Given this list of marker genes SKIC2, THOC1, EIF3H (NCBI Gene Id 8667), NEK11, MRPS18B, LETMD1, CYREN, RIN2, MOV10, GOLT1B (golgi transport 1B), NUDT5, RALY, SETDB1, WSB1, ZNF518A, TMEM87A, NAA20, MARK2, BBS4, RARB, MRPS31, OXNAD1, RECQL5, FBXO38, ZNF24, BANF1, ZSCAN9, COPS5, USP48, DLEU2, YTHDC1, TXNL1, SPAG7, ZNF615, GORAB, CWF19L1 (NCBI Gene Id 55280), HCK, NUP155, TRAPPC1, THRAP3, NME7, CHMP2B, NEPRO, RNF20, NELFE, MBD1, HOXA1, ARPC4, NECAP1, PDCD10, LINC00877, NUDT2, SERPINI1, KNTC1, SHCBP1 (NCBI Gene Id 79801), OS9, MCTS1, ZNF600, MTPN, PPP2R3C, MUL1, ARL14EP, FLCN, ERCC1, MYOF, SLC26A6, GOSR2, SELENOK, CLPTM1 (NCBI Gene Id 1209), DCTN4, VPS41, THUMPD3, SUPV3L1, ZNF222, CCNT1, CDC123, KRR1, CCDC174, UBR1, H2AC20, IP6K2, CDCA5, KDM3A, TBC1D32 (NCBI Gene Id 387102), ORC4, PNISR, NOL6, BLZF1, ENSA, FGF13, MPV17, DPH3, DMAC2, PSMA3 (NCBI Gene Id 5684), CAMTA2, NDUFA5, TADA3, NSRP1, ZMPSTE24, PNPT1, ZC3H4, ZFPL1 (zinc finger protein like 1), RNPC3, RSRC2, POP4, CHMP4B, CAP1, ADAT1, ZGRF1, MIPOL1, ZBTB3, LARP7, H2BC21, EIF1AD, AP3B1, SERINC3, VPS37B, CDKAL1, SENP7, PRRC2C, MED7, GOLGB1, TTI2, H4C5, CNTROB, RECQL, FBXO38-DT, GOSR1, DEDD, PSMC4, JPH1, SEC23B, UQCRC2, ASTE1, DDX39B, PSMA6 (NCBI Gene Id 87553), VPS39, LINC02453, here is a description of the gene set: from publication Nouzova M, Holtan N, Oshiro MM, Isett RB, Munoz-Rodriguez JL, List AF, Narro ML, Miller SJ, Merchant NC, Futscher BW (PMID 15302897) Dysregulation of epigenetic control is an important participant in carcinogenesis. The PML/RAR alpha translocation in acute promyelocytic leukemia (APL) is an example where the resultant fusion protein recruits histone deacetylase complexes to target genes resulting in their inappropriate transcriptional repression. All-trans-retinoic acid (ATRA) acts as a ligand that relieves this repression and produces an epigenetic transcriptional reprogramming of the cancer cell. CpG island microarrays were used to analyze the DNA methylation and histone acetylation state of the human APL cell line NB4 before and after differentiation with ATRA as well as normal peripheral blood mononuclear cells (PBMC). Over 70 CpG islands within 1 kb of transcription start of a known gene are aberrantly methylated in NB4 cells compared with PBMC; however, no changes in cytosine methylation were detected following ATRA-induced differentiation. With respect to histone H4 acetylation, over 100 single-copy CpG islands within 1 kb of transcription start of a known human gene became hyperacetylated following ATRA-induced differentiation. One CpG island was aberrantly methylated in NB4 cells, but became hyperacetylated and was induced following ATRA treatment and was associated with the HoxA1 gene, suggesting it may be a target gene of ATRA in APL. In addition to single-copy sequences, a selective increase in acetylation was detected in satellite DNA when compared with other high-copy sequences, such as Alu or rDNA. In summary, ATRA stimulates complex epigenomic changes during leukemic cell differentiation, and monitoring these changes may help to identify new targets of epigenetic dysfunction. Genes whose CpG islands showed greatly increased histone H4 acetylation in NB4 cells (acute promyelocytic leukemia, APL) upon treatment with tretinoin. Human Gene Set: NOUZOVA_TRETINOIN_AND_H4_ACETYLATION studied in species Homo sapiens